The following is a description of a gene set: studied in species Mus musculus Mouse Gene Set: GOBP_POSITIVE_REGULATION_OF_POTASSIUM_ION_TRANSMEMBRANE_TRANSPORTER_ACTIVITY Any process that activates or increases the frequency, rate or extent of potassium ion transmembrane transporter activity., and this is the list of marker genes: Actn2, Galr2, Nppa, Rnf207, Akap9, Gal, Atp1b3, Lrrc26, Lrrc52, Akap6, Lrrc55, Atp1b1, Atp1b2, Lrrc38, Akap7, Ank2